The following is a description of a gene set: studied in species Homo sapiens from publication Chen Y, Wang X (PMID 31504780) Genes predicted to be targets of miRBase v22 microRNA hsa-miR-1267 in miRDB v6.0 with MirTarget v4 prediction scores > 80 (high confidence targets). Human Gene Set: MIR1267, and this is the list of marker genes: FIBIN, ESRRG, ZNF37A, DIO1, MBNL2, TOE1, DYNC1I2, PLEKHM1, SHROOM2, CYBB, CSRNP3, ALG9 (ALG9 alpha-1,2-mannosyltransferase), SALL1, CDK1, ZNF682, ANKS1B, LHFPL3, RIC8B, ANTXR1, BNIP3, ZFYVE1, MAN2A1, FAM91A1, PRKG1, MDFIC, SCUBE1, PTPRO, SOX21, PTGER3, FRK, TMEM196, BBS10, RUFY2 (RUN and FYVE domain containing 2), ZBTB24, SCN1A, MMP13, RNF114 (ring finger protein 114), GNRHR, ELMOD2, ITPRID1, SPOCK3, RAD17, PKHD1, COL11A1, ARHGAP27, RUNX1T1, ZBTB26, ITGA6, DIO2, ABCB10, TUBE1, MBOAT2, USP42, ZNF195, DDI2, SMIM8, LYNX1, TNFSF13B, ARHGAP32, PPBP, FUT8, GPR4, ZBTB1, ZDHHC17, CAMK2D, C5AR2, MAP3K12, ANO8, SKA3, PRKD1, PHYH, ZNRF3, GALT, CFAP91